The following is a description of a gene set: studied in species Homo sapiens Human Gene Set: AMIT_SERUM_RESPONSE_120_MCF10A Signaling pathways invoke interplays between forward signaling and feedback to drive robust cellular response. In this study, we address the dynamics of growth factor signaling through profiling of protein phosphorylation and gene expression, demonstrating the presence of a kinetically defined cluster of delayed early genes that function to attenuate the early events of growth factor signaling. Using epidermal growth factor receptor signaling as the major model system and concentrating on regulation of transcription and mRNA stability, we demonstrate that a number of genes within the delayed early gene cluster function as feedback regulators of immediate early genes. Consistent with their role in negative regulation of cell signaling, genes within this cluster are downregulated in diverse tumor types, in correlation with clinical outcome. More generally, our study proposes a mechanistic description of the cellular response to growth factors by defining architectural motifs that underlie the function of signaling networks. Genes whose expression peaked at 120 min after stimulation of MCF10A cells with serum. from publication Amit I, Citri A, Shay T, Lu Y, Katz M, Zhang F, Tarcic G, Siwak D, Lahad J, Jacob-Hirsch J, Amariglio N, Vaisman N, Segal E, Rechavi G, Alon U, Mills GB, Domany E, Yarden Y (PMID 17322878), and this is the list of marker genes: TRIM21, SOWAHC, ID1, PPP2R5D, PDZD2, CXCL10, ATP8B1, KLF10, CDKN1C, BCAR3, JUNB, DUSP10, CLCF1, DLX2, C3orf52, NEDD9, GADD45A, TESK1, SPHK1, ID2 (inhibitor of DNA binding 2), RAP2B, YRDC, EDN1, GCNT1, EZR, CDR2L, CSTF2, PLAGL2, KLF5, FEM1B, KLF4, MAP3K14, LIF, SKIL, GADD45B, IRS2, SUN1, MCL1, IFIT5, MNT, BMP2, SETD3, ID3, ESRP2, SCHIP1, ISOC1, GBP1, IL36G, SERTAD3, PIM1, DAPP1, FERMT2, SIK1, CD55, RYBP, SOX9, ETS2, KRT10, MAFF, PLAUR, STX12, RND3, PDLIM5, CIZ1, MREG